Given this list of marker genes RARA, HOXA5, WNT7B, RSPO2, RARG, SOX9, SRF, here is a description of the gene set: The process whose specific outcome is the progression of the tracheal cartilage over time, from its formation to the mature structure. Cartilage is a connective tissue dominated by extracellular matrix containing collagen type II and large amounts of proteoglycan, particularly chondroitin sulfate. Human Gene Set: GOBP_TRACHEA_CARTILAGE_DEVELOPMENT studied in species Homo sapiens